Given this list of marker genes ARPC5, MAPK8, MAP2K4, RAC1, CFL1, MAP3K1, ATF2 (NCBI Gene Id 1386), STAT3 (signal transducer and activator of transcription 3), NOXO1, NCF1, ABI1, PLCB2, CYFIP2, MAPK14, JUN, CTNNB1, PIP5K1B, BRK1 (BRICK1 subunit of SCAR/WAVE actin nucleating complex), ARPC1B, RACGAP1, CRK, NOXA1, ACTR3, PIP5K1C, ARHGAP5, IQGAP3, NCF2, MAP2K3, MAP2K7, NOX1, CDH1, CTNNA1, ARPC4, STAT5A, MAP3K11, ARPC3, LIMK1, ARHGDIA, CYBA, IQGAP1, ABI2, MAP2K6, WASF1, PAK2, MAPK9, CYBB, ACTR2, ARPC2, PIP5K1A (NCBI Gene Id 8394), BAIAP2 (NCBI Gene Id 10458), WASF2, BCAR1, PAK1, NCKAP1, here is a description of the gene set: Human Gene Set: PID_RAC1_PATHWAY RAC1 signaling pathway species: Homo sapiens from publication Schaefer CF, Anthony K, Krupa S, Buchoff J, Day M, Hannay T, Buetow KH (PMID 18832364)